The following is a description of a gene set: Remodeling the acyl chains of premature (de novo synthesized) cardiolipin (1,3-bis(3-phosphatidyl)glycerol), through sequential deacylation and re-acylation reactions, to generate mature cardiolipin containing high-levels of unsaturated fatty acids. studied in species Mus musculus Mouse Gene Set: GOBP_CARDIOLIPIN_ACYL_CHAIN_REMODELING, and this is the list of marker genes: Tafazzin, Hadha, Them5, Pla2g5, Pla2g6, Lclat1